The following is a description of a gene set: Mouse Gene Set: REACTOME_DOWNSTREAM_TCR_SIGNALING Downstream TCR signaling species: Mus musculus, and this is the list of marker genes: Psmb5, Psmb2, Malt1, Cd4 (CD4 antigen), Psma5, Psmb6, Ube2n, Map3k7, Skp1, Psmb7 (NCBI Gene Id 19177), Psmc5, Bcl10, Ube2d2a, Rela, Pik3ca, Ripk2, Cdc34, Prkcq, Psmb1, H2-Eb1, Fbxw11, H2-Ea, Pik3cb, Trbv16, Psmc6, Lck, Adrm1, Uba52, Psma6, Psmb4, Psmd14, Ubb, Psmd12, Ikbkb, Cd247, H2-Aa, Psmb3, Psma3, Nfkbia, Ubc, Psmd2, Trav16 (NCBI Gene Id 195297), Psmd8, Psmd11, Cul1 (NCBI Gene Id 26965), Psmd3, Inpp5d, H2-Eb2, Cd3d, Rps27a, Cd3g, Trbv15, Psma4, Traf6, Ube2v1, Psmd7, Uba52rt, Psmd13, Ube2d1 (NCBI Gene Id 216080), Pten, Trac, Card11 (caspase recruitment domain family, member 11), Psmc2, Ikbkg, Pdpk1, Psma1, Tab2, Psma7 (NCBI Gene Id 26444), Chuk, Trav19, Cd3e, Psmd1, Psmc1, Nfkb1, Psmc4 (proteasome (prosome, macropain) 26S subunit, ATPase, 4), Trat1, Pik3r1, Psmd6, H2-Ab1, Pik3r2, Psma2, Psmc3